Given this list of marker genes Cxcl2, Anxa1, Mrc1, Sirpa, Msr1, Tgfbi, Cpt1a, Ms4a6d, Camk2d, Plek, Aqp9, Cd300lf, Pilrb1, Chil3, Klra2, Phlda1, Lsp1, Slfn2, Dab2, Lcn2, Samhd1, Csf1r, Ffar2, Lpl, Mmp8, P2ry14, Ccr5, Car4, Fpr1, Grk5, Klf4, Plscr1, Ctsl, Arg2, Zfp36l1, Mertk, Csf2rb2, Slc11a1, Ear1, S100a4, Ccn3, Il1r2, H1f2, Upp1, Lipa, C3ar1, Zfp36, Gcnt2, Tpd52, Lilrb4b, Fpr2, Anxa4, Tlr2, Mcl1, Egr2, Mitf, Ctss, Btg2, Il1b (NCBI Gene Id 16176), Gpr137b, Mpeg1, Id2, Vcan, Mmp9, Ccl6, Psap, Il18, Fgr, Ndrg1, Hck, Egr1, Lyz2, Stx3, Dusp1, Clec7a, Fos (FBJ osteosarcoma oncogene), Cybb, Ehd1, Cdh1, Litaf, C5ar1, Trpv2, Fcgr1, Clec4a2, Trf, Myadm, here is a description of the gene set: studied in species Mus musculus from publication Hess JL, Bittner CB, Zeisig DT, Bach C, Fuchs U, Borkhardt A, Frampton J, Slany RK (PMID 16507773) Genes down-regulated in hematopoietic precursor cells conditionally expressing HOXA9 and MEIS1. Mouse Gene Set: HESS_TARGETS_OF_HOXA9_AND_MEIS1_DN Abdominal-type HoxA genes in combination with Meis1 are well-documented on-cogenes in various leukemias but it is unclear how they exert their transforming function. Here we used a system of conditional transformation by an inducible mixed lineage leukemia-eleven-nineteen leukemia (MLL-ENL) oncoprotein to overexpress Hoxa9 and Meis1 in primary hematopoietic cells. Arrays identified c-Myb and a c-Myb target (Gstm1) among the genes with the strongest response to Hoxa9/Meis1. c-Myb overexpression was verified by Northern blot and quantitative reverse transcription-polymerase chain reaction (RT-PCR). Also MLL-ENL activated c-Myb through up-regulation of Hoxa9 and Meis1. Consequently, short-term suppression of c-Myb by small inhibitory RNA (siRNA) efficiently inhibited transformation by MLL-ENL but did not impair transformation by transcription factor E2A-hepatic leukemia factor (E2A-HLF). The anti c-Myb siRNA effect was abrogated by coexpression of a c-Myb derivative with a mutated siRNA target site. The introduction of a dominant-negative c-Myb mutant had a similar but weaker effect on MLL-ENL-mediated transformation. Hematopoietic precursors from mice homozygous for a hypo-morphic c-Myb allele were more severely affected and could be transformed neither by MLL-ENL nor by E2A-HLF. Ectopic expression of c-Myb induced a differentiation block but c-Myb alone was not transforming in a replating assay similar to Hoxa9/Meis1. These results suggest that c-Myb is essential but not sufficient for Hoxa9/Meis1 mediated transformation.